Given this list of marker genes FOXE3, PLXND1, EHMT1, ZMPSTE24, SZT2, MFAP5, IFNGR1, LMNA, ARF1, THSD4, LOX, GNPTG, SMAD3, FBLN5, TGFB2, SPRED2, ADA2, PCGF2, PDSS1, CEP57, HEY2, GJA8, C4A, SKIC3, GATA5, BUB1, IDUA (NCBI Gene Id 3425), NOTCH1, SMAD6 (SMAD family member 6), ERAP1, SLC2A10, MAPK1, NKX2-6, FBN1, TBX1, BCR, CCR1, TAB2, KIFBP, GATA4, IL12A-AS1, ALDH18A1, STAT4, LMOD2 (leiomodin 2), MAN2B1, DYRK1A, C12orf57, FLNA, UBAC2, HLA-B, CHST14, IL12A, BUB1B, CHST3, PUF60, SLC35A1, MYH11, IL23R, TGFB3, KLRC4, TMTC3, SON, SMAD4, MEFV, ATP6V1E1, MAP1B (microtubule associated protein 1B), GJA5, TLR4, HEATR3 (HEAT repeat containing 3), IL10 (NCBI Gene Id 3586), SPTBN1, ERMARD, CCNQ, ARSK, TGFBR2, MLX, MAT2A, ARFGEF2, FAS, D2HGDH, TRIP13, ELN, NKX2-5, SKIC2, PEX2, SHOC2, HCN4, NEDD4L, IL12B, YY1AP1, GNPTAB, COL1A2, ADAMTS19, COA6, MYLK, ACTA2, TGFBR1, BUB3, IFT56, PRKG1, CRKL (CRK like proto-oncogene, adaptor protein), SMAD2, DOHH, here is a description of the gene set: Aortic regurgitation species: Homo sapiens An insufficiency of the aortic valve, leading to regurgitation (backward flow) of blood from the aorta into the left ventricle. Human Gene Set: HP_AORTIC_REGURGITATION